The following is a description of a gene set: Mouse Gene Set: MIR_3097_3P species: Mus musculus from publication Chen Y, Wang X (PMID 31504780) Genes predicted to be targets of miRBase v22 microRNA mmu_miR_3097_3p in miRDB v6.0 with MirTarget v4 prediction scores > 80 (high confidence targets)., and this is the list of marker genes: Dusp18, Cyp2b10, N4bp2l1, Pmepa1, Greb1l, Srsf7, Atp8a1, Sdha, Ggta1, Palld, Wee1, Cflar, Hoxd3, Itpk1 (inositol 1,3,4-triphosphate 5/6 kinase), Tlr7, Lrrc8a, Rab12, Pitx3, Pik3r1, Hccs, Commd8, Gabpa (GA repeat binding protein, alpha), Samd7, Fndc1, Rnf40, Khdc1b, Ppm1e, Rfx7, Grm1 (NCBI Gene Id 74875), Mthfr, Sfxn2, Smg7, Timm13, Fam149a, Colgalt2, Kcnh8, P2ry10, Tyro3, Rpf1, Trmt2b, Picalm, Timmdc1, Jaml, Ddit4 (DNA-damage-inducible transcript 4), Arrdc2, Slx1b, Vapb, Gm10408, Dip2b, Kmt2e, Mab21l1, Hsp90aa1, D830030K20Rik, Sall4, Zfp60 (NCBI Gene Id 76165), Tnfaip8, Srsf10, Naa50, Eif2ak3, Slc6a17, Slc15a1